Given this list of marker genes RYR2, PLEK, ANXA3, RAC3, PPIF, DKK1, RAB3C, ENSG00000233968, PTGER3 (NCBI Gene Id 5733), EXOC3L4, GSTT2B, HTR2A, VWF (NCBI Gene Id 7450), SMAD3-DT (NCBI Gene Id 102723493), MLEC (malectin), KALRN, MED12L, ADRA2A, ADCY6, PIEZO2, CDH6, LTC4S, DTD1, TCEAL9, TPI1, IGSF10, NAA38, TPM1, ACTN1, TTC27, RBPMS2, PBX1, GATA2, KAZN, SLC37A1, GLOD5, ITGA2, MMRN1, ITGA2B, TRPC6, STUM (stum, mechanosensory transduction mediator homolog), COL2A1, OLFM3, ST6GAL2, SLC18A2, GJA4, MGLL, MYH7, ITPKA, TGFB1I1, EFHC2, GUCY1B1, EFNB2, PDIA5, LTBP1 (latent transforming growth factor beta binding protein 1), PRTFDC1, WFDC1, KLHL13, SPX, PRKG1, RAB38, STAC, DAD1, TEAD4, here is a description of the gene set: from publication Hay SB, Ferchen K, Chetal K, Grimes HL, Salomonis N (PMID 30243574) Human Gene Set: HAY_BONE_MARROW_CD34_POS_MKP species: Homo sapiens